The following is a description of a gene set: studied in species Homo sapiens Genes up-regulated in control CD4 T cells versus those infected with HIV-1 viruses lacking Env and Nef. from publication Dabrowska A, Kim N, Aldovini A (PMID 19050264) The high mutation rate of HIV is linked to the generation of viruses expressing proteins with altered function whose impact on disease progression is unknown. We investigated the effects of HIV-1 viruses lacking Env, Vpr and Nef on CD4+ T cell gene expression using high-density DNA microarray analysis and functional assays. Human Gene Set: GSE12963_UNINF_VS_ENV_AND_NEF_DEFICIENT_HIV1_INF_CD4_TCELL_UP, and this is the list of marker genes: HECW1, WAS, AMER1, ARIH2, SIKE1, PRRT1, FAM83A, CACNB3, TMEM229B, FMNL1, MIR181D, FRMD6, RTL6, FAM117B, SMAD3, SLC39A3, RTBDN, FADS3, IRF7, GSTT1, ZBTB25, NGRN, CHGB, LPO, IRX4, ATXN7L1, EHMT1, TAF8, GALNT10, B4GALT6, FKBP14, SETD1B, IQCA1, ARFGEF2, PRRX2, FAM50A, TRIM26, DEFB4A, CRP, CLDN4, DYNC1LI2, ZCCHC9, GRAP2, PTPRU, HMBOX1, DLX2, DHX16, GLRB, S100Z, AMH, SP2, ADRA1D, HSPBAP1, ISCU, WDR33, PNMA5, SMAD5, CLCN7, DNAJC5, TTC38, MIGA2, ASB13, NCDN, ORAI2, TH, ZSWIM2, MEPCE, TGFBR3, CD3E, FAM168B, KCNK2, DYNLT5, TRIM42, CACNA1H, CYB561D1, GRIK4, CRTC3, SUFU, CLCN2, IFNGR2, RNF123, MOSPD3, XKR8, CLTA, SALL1, SLC1A3, GIGYF1, RFPL4B, ZBTB4, DHH, AK7, UBALD1, UBE2J2, PARVA, TRAPPC5, CHRM1, PARP12 (NCBI Gene Id 64761), PNMT, GP1BA, PTK2B, RPL18, PCDHB15, GARIN5A, KCNH2, CLCA4, AGO1, BAIAP2L1, SIAH3, TOR3A, KLHL42, PJA1, PAF1, TMEM174 (NCBI Gene Id 134288), RPS14, SBF1, MAPDA, KRT2, SFN, GNG3, CACNA1F, NEU4, SLC30A9, C1QC, KRT6A, TREH, TNRC18, TSC22D3, KRT26, CDYL, EFHD1, SLC35B3, AXIN1, PURG, WWP2, SIPA1L3, PPFIA4, MMP16, TACO1 (NCBI Gene Id 51204), ITPKC, TRIM52, SUN5